Given this list of marker genes RHD, RHCE, here is a description of the gene set: part of: Blood group systems biosynthesis studied in species Homo sapiens The Rhesus (Rh) blood group system (including the Rh factor) is the second most important blood group system after the ABO blood group system. The Rh blood type was first discovered in 1937 by Karl Landsteiner and Alexander S. Wiener who named it after the rhesus macaque whose RBCs were used to generate the rabbit immune serum that first detected the human blood group system. Subsequent studies by them and Philip Levine and Rufus Stetson identified the antigen that induced this immunization as the "Rh factor" and also its association with hemolytic disease of the newborn (Levine & Stetson 1984, Landsteiner & Wiener 1941). Of the 50 defined Rh blood group antigens, five (D, C/c and E/e) are the major types expressed by the <i>RHD</i> and <i>RHCE</i> genes in the <i>RH</i> gene complex. Rh antigens are expressed on red cell (RBC) membranes in association with other membrane proteins and this whole complex interacts with the spectrin-based skeleton and contributes to the maintenance of the mechanical properties of the RBC membrane (Van Kim et al. 2006).<br><br>The <i>RHD</i> gene produces the D antigen, the most immunogenic Rh antigen. The term "Rh factor" refers only to the D antigen; Rh positive (Rh+) individuals have the D antigen on their RBC membranes whereas Rh negative (Rh-) individuals don't. Humans are not born with antibodies towards the D antigen in their blood, they have to be exposed to it (through blood transfusion or placental exposure during pregnancy) at some point in their lives before antibodies are made against it. Once exposed, however, Rh+ individuals remain sensitive for the rest of their lives. Importantly, if individuals are Rh+ and are exposed to Rh- blood, no immune response is mounted. Anti-D antibodies are only seen if an individual is lacking the D antigen (Rh-) and is exposed to Rh+ blood. The <i>RHCE</i> gene produces polypeptides with C/c and E/e antigens.<br><br>These polypeptides are the core components of their respective antigens but by themselves are devoid of the immunoreactivity which defines the Rh antigens. The remaining antigens are produced by partial deletion, recombination, mutation, or polymorphisms of one or both <i>RHD</i> and <i>RHCE</i> genes. Together, these antigens form the most complex and polymorphic blood group system based on the multitude of phenotypes that can be expressed on the RBC surface. The Fisher-Race system, the nomenclature used most commonly, uses the CDE system to depict the notation of Rh genotypes. The most common group of genes inherited is CDe with ce (D negative) being the second most common. Rh genotyping is used in blood transfusion, paternity testing and to determine the risk of hemolytic disease of the newborn. Reactome Pathway: Rhesus blood group biosynthesis